Given this list of marker genes MIR133A1, KCNJ5, NOS1, DLG1, KCNH2, SCN2B, KCNE3, KCNQ1, MIR1-1, CASQ2, RNF207, KCNE2, KCNJ8, KCNE1, KCNE5, KCND3, KCNJ3, NOS1AP, KCNE4, here is a description of the gene set: The process in which ions are transported across a membrane such that the ventricular cardiomyocyte membrane potential changes in the direction from the positive membrane potential at the peak of the action potential towards the negative resting potential. studied in species Homo sapiens Human Gene Set: GOBP_MEMBRANE_REPOLARIZATION_DURING_VENTRICULAR_CARDIAC_MUSCLE_CELL_ACTION_POTENTIAL